The following is a description of a gene set: Mouse Gene Set: MIR_5621_3P from publication Chen Y, Wang X (PMID 31504780) studied in species Mus musculus Genes predicted to be targets of miRBase v22 microRNA mmu_miR_5621_3p in miRDB v6.0 with MirTarget v4 prediction scores > 80 (high confidence targets)., and this is the list of marker genes: Smg5, Ednra, Macf1, Slx4, Camk2n2, Pold4, Elovl5, Slc31a2, Sypl2, Tub, Clcn1 (chloride channel, voltage-sensitive 1), Tshz2, Mmab, Kcnj4, Naa15, Neurl4, Rsf1, Ndor1, Stac2, Cmtm3, Lfng, Dyrk1a, Efna1, Usp9x, Ccr5, Camk2b (calcium/calmodulin-dependent protein kinase II, beta), Ost4, Brpf1, Ube2j1, Scrt1, Csf3 (colony stimulating factor 3 (granulocyte)), Abcc1, St3gal3, Igsf9b, Ptges2, Hcfc1, Hspa4l, Dolpp1, Synpr, Esrrb, Hes5, Ssna1, Cacna1e, Cmtr1